Given this list of marker genes Hs3st4, Hs3st6, Hs3st5 (heparan sulfate (glucosamine) 3-O-sulfotransferase 5), Hs3st3b1, Hs3st2, Hs3st1, Hs3st3a1, here is a description of the gene set: species: Mus musculus Catalysis of the reaction: alpha-D-glucosaminyl-(n) + 3'-phosphoadenylyl sulfate = 3-sulfo-alpha-D-glucosaminyl-(n) + adenosine 3',5'-bisphosphate + H+. Mouse Gene Set: GOMF_HEPARAN_SULFATE_GLUCOSAMINE_3_SULFOTRANSFERASE_ACTIVITY